The following is a description of a gene set: from publication Martoriati A, Doumont G, Alcalay M, Bellefroid E, Pelicci PG, Marine JC (PMID 15608685) Genes down-regulated in apoptotic tissues (neuroepithelium) after MDM4 knockout. Human Gene Set: MARTORIATI_MDM4_TARGETS_NEUROEPITHELIUM_DN The p53 tumour suppressor functions as a transcriptional activator, and several p53-inducible genes that play a critical proapoptotic role have been described. Moreover, p53 regulates the expression of various proteins participating in autoregulatory feedback loops, including proteins that negatively control p53 stability (Mdm2 and Pirh2) or modulate stress-induced phosphorylation of p53 on Ser-46 (p53DINP1 or Wip1), a key event for p53-induced apoptosis. Here, we describe a new systematic analysis of p53 targets using oligonucleotide chips, and report the identification of dapk1 as a novel p53 target. We demonstrate that dapk1 mRNA levels increase in a p53-dependent manner in various cellular settings. Both human and mouse dapk1 genomic loci contain DNA sequences that bind p53 in vitro and in vivo. Since dapk1 encodes a serine/threonine kinase previously shown to suppress oncogene-induced transformation by activating a p19ARF/p53-dependent apoptotic checkpoint, our results suggest that Dapk1 participates in a new positive feedback loop controlling p53 activation and apoptosis. studied in species Mus musculus, and this is the list of marker genes: BHLHE22, PARP9, RGS4, MYB, MTURN (maturin, neural progenitor differentiation regulator homolog), EDNRB, RSPO2, NUDT21 (nudix hydrolase 21), GDAP1, CSF2RB, NAP1L2, ZBTB18, IRF2BPL, KCNA5, DMRTA2, PKIA, PKNOX1 (NCBI Gene Id 5316), CADPS (NCBI Gene Id 8618), TAL2 (NCBI Gene Id 6887), TP53INP2, HSD17B11, ARCN1, REM2, RIPPLY3, CTSC, DUXB, ID4 (NCBI Gene Id 3400), ZRANB1, FRMD5, FMN2, TAL1, ENY2, RBL1, CSF1R, SATB1, NSG1, HEMGN (hemogen), FGD4, SCG3, ITGB8, CADM4, RUFY3, DBX1, POU3F4, ATAT1, FSTL5, DLX6-AS1, NHLH2, FOXG1, MAPK10, PEA15, UNCX, HPGD, SLC17A6, TMEM26, RTN1, PRMT8, MDM4, ELAVL3, MIR9-3HG, SANBR, RNH1, BRSK2, DCX, MYT1, ASCL1, SCRN1, ALDH1A1, SKOR1, NEUROG1, CNMD, MAF, MPPED2, PAK1, EGFL6, C1QTNF3, APC2, ACSS1, JAKMIP2 (janus kinase and microtubule interacting protein 2), EOMES, CXCL13, TBR1, PLCXD2, NEUROD1, F13A1, STMN2, CX3CR1, XIST, IGFBPL1, DLX5, CORO1A, TCAF1, CD53 (NCBI Gene Id 963), RNF182, ADGRG1, IGFBP5 (insulin like growth factor binding protein 5), RND2, FOS, ZCCHC18, OXCT1, UBXN2A, GREM2, C1QB, LY86, TLCD4 (TLC domain containing 4), BRINP1, INA (NCBI Gene Id 9118), C4orf3, MEGF9, SLC4A5, NEUROD4, STX3, MIR100HG, PGM2L1, LST1, ELAVL4, ABCD2, SHOX2, HDAC9, KIF21A, FYN, CNR1, MRC1, TSPYL4, ELAVL2, SCARA3, STMN3, PDGFRA, RHBDL3, GFRA1, NOL4, TTYH1, GPM6B, MTCL3, PCDH9, AGO1, INSIG1, MIR9-2HG, ZMAT1, CACNG4, GSX1, CFL2 (NCBI Gene Id 1073), MAP2, FABP7, SYT11, VCAM1, SGK3, KAT2B, CD1D, C14orf132, PPP1R17, RAPGEF5, DACH1, SPAST, JAM2, LRRN1, SCG5, TYROBP, ERMAP (erythroblast membrane associated protein (Scianna blood group)), ST8SIA4, HAND2, BCL11A, CDK5R1, NCAN